The following is a description of a gene set: studied in species Mus musculus Binding to a transcription coactivator, a protein involved in positive regulation of transcription via protein-protein interactions with transcription factors and other proteins that positively regulate transcription. Transcription coactivators do not bind DNA directly, but rather mediate protein-protein interactions between activating transcription factors and the basal transcription machinery. Mouse Gene Set: GOMF_TRANSCRIPTION_COACTIVATOR_BINDING, and this is the list of marker genes: Gata6, Thrb, Zbtb17, Rara (retinoic acid receptor, alpha), Ccnt2, Rora, Nr3c2, Atf7, Pgr, Nfatc1, Tfam, Stat1, Stat6, Trerf1, Cit (citron), Smad3, Lhx3, Ppard, Zbtb49, Nr4a3, Map3k7, Crebbp, Tert, Ppara (NCBI Gene Id 399624), Rxra, Gata3, Gata1, Six1, Smad4 (SMAD family member 4), Gata4, Rela, Zbtb8a, Esr1, Ahr, Foxo1, Ep300, Pparg, Hnf1a, Hif1a, Gata2, Cdk9, Hand2, Med25, Ar, Rorc, Epas1, Rpl23, Med1, Flywch1, Runx1, Creb1, Med6, Vgll4, Tead2